The following is a description of a gene set: Human Gene Set: GOBP_SEGMENT_SPECIFICATION The process in which segments assume individual identities; exemplified in insects by the actions of the products of the homeotic genes. species: Homo sapiens, and this is the list of marker genes: DLL1 (delta like canonical Notch ligand 1), HOXA2, BMI1, MEOX2, IRX1 (NCBI Gene Id 79192), RIPPLY1, HES5, MEOX1, MTF2, IRX2, OSR1, COBL, MLLT3, IRX3, DVL2, MSGN1, MAFB